Given this list of marker genes Rxfp4, Rln3, Rxfp2, Rxfp3, Insl5, here is a description of the gene set: studied in species Mus musculus electronically inferred by orthology from the curated human pathway part of: Peptide ligand-binding receptors Reactome Pathway: Relaxin receptors This event has been computationally inferred from an event that has been demonstrated in another species.<p>The inference is based on the homology mapping from PANTHER. Briefly, reactions for which all involved PhysicalEntities (in input, output and catalyst) have a mapped orthologue/paralogue (for complexes at least 75% of components must have a mapping) are inferred to the other species.